Given this list of marker genes TCP1, IFITM3, CACNA1E, ARAP1, SRM, LYPD2, H2AZ1, HOMER3, SRSF1, PATJ, SPRR2A, TTLL11 (NCBI Gene Id 401550), ACTA2, NCAN, GNAO1, KLF13, CD248 (NCBI Gene Id 57124), DYNLT2B, VPS37A, ARHGAP4, MAP6, HAMP, CITED2, WFDC2, SPIC, LHX3, LY6E, POLR1HASP, ICAM1, PFKL (phosphofructokinase, liver type), RPS6KA4, GSK3B, TP73, PDCD5, AXL, FOXL2, CX3CL1, RHOH, PPIC, CHPT1, HBE1, SMU1, MRPS18A, TGFA, CPA5, ACTG2, FTL, ARL2, GKN3P, SNHG9, CCT4, KLK9, OVOL2 (NCBI Gene Id 8197), EEF1B2, BZW1, CAPN2, DNAJC1, PLAC8, GABARAPL2, MAP2K5, CEACAM21, RBM12, NPTXR, EXT2, NUF2, GPR15LG, NCL, CLVS1, LTB4R, ESD, CCDC38, SNHG3, BBLN, GBA1, RAB5IF, PAQR7, RNF181, PTPRCAP, IRAK1, APOD, ACAN, RPS3A, STX16, SPNS3, ENG, S100A8, DYNLL1, SPP1, PGK1, CA3, TRMT1, IDE, LYZ, TNP2, PLEKHA4, ID1, NRSN1, ATP6V0D1, TMEM248, YWHAB, UBE2C, SOD1, PGAM1, BATF3, LTBP4, DRD5, LCE3B, LRIF1, RYR1 (ryanodine receptor 1), RAB2B (NCBI Gene Id 84932), ENAH, RUBCN, TRAF2, CRELD1, MAN2A2, CXCL16, CHI3L1, S100A9, COX5B, CMPK2, FABP4, HBS1L (NCBI Gene Id 22991), PRG3, LIF, SOD3, BAIAP2, CHKA, CHP1 (NCBI Gene Id 11261), ART5, ENO1, EML4, QDPR, ACOT9, LDHA, MAP1LC3A, SDR9C7, PLET1, NHP2, SSU72, MCAM, ELAVL1, CTSV, SUN1, SLPI, TMEM65 (transmembrane protein 65), here is a description of the gene set: Human Gene Set: DARWICHE_SKIN_TUMOR_PROMOTER_UP Genes up-regulated during skin tumor progression: epidermis treated with the carcinogen DMBA followed by 20 weekly applications of the tumor promoter TPA, compared to the untreated skin. from publication Darwiche N, Ryscavage A, Perez-Lorenzo R, Wright L, Bae DS, Hennings H, Yuspa SH, Glick AB (PMID 17525749) Chemical induction of squamous tumors in the mouse skin induces multiple benign papillomas: high-frequency terminally benign low-risk papillomas and low-frequency high-risk papillomas, the putative precursor lesions to squamous cell carcinoma (SCC). We have compared the gene expression profile of twenty different early low- and high-risk papillomas with normal skin and SCC. Unsupervised clustering of 514 differentially expressed genes (P<0.001) showed that 9/10 high-risk papillomas clustered with SCC, while 1/10 clustered with low-risk papillomas, and this correlated with keratin markers of tumor progression. Prediction analysis for microarrays (PAM) identified genes that distinguished the two papilloma classes, and a majority of these had a similar expression pattern in both high-risk papillomas and SCC. Additional classifier algorithms generated a gene list that correctly classified unknown benign tumors as low- or high-risk concordant with promotion protocol and keratin profiling. Reduced expression of immune function genes characterized the high-risk papillomas and SCC. Immunohistochemistry confirmed reduced T-cell number in high-risk papillomas, suggesting that reduced adaptive immunity defines papillomas that progress to SCC. These results demonstrate that murine premalignant lesions can be segregated into subgroups by gene expression patterns that correlate with risk for malignant conversion, and suggest a paradigm for generating diagnostic biomarkers for human premalignant lesions with unknown individual risk for malignant conversion. studied in species Mus musculus